The following is a description of a gene set: species: Mus musculus Mouse Gene Set: GOCC_NEURON_PROJECTION A prolongation or process extending from a nerve cell, e.g. an axon or dendrite., and this is the list of marker genes: Gabbr2, Homer2, Itsn1, Tmod2, Dlg3, Amfr, Npy1r, Clstn2, Rom1, Elmod3, Syt13, Chrna10, Aatk, Prnp, Hmcn2, Mir18, Psd2, Zfyve27, Polg, Hspa8, Drd1, Dlgap3, Tgfb2, Prcd, Fyn, Trpm5, Casc3, Ghsr, App, Grid2ip (glutamate receptor, ionotropic, delta 2 (Grid2) interacting protein 1), Iqcb1, Syp, Bnip3, Dynll1, Vti1a, Crhr1, Scn1a, Kcnip2 (Kv channel-interacting protein 2), Tubb3, Shisa9, Sstr1, Prkn, Sptbn1, Lama2, Lmtk2, Amph, Flrt3, Glrx2, Psmc2, Gabrb2, Zfp804a, Gabra3, Fas, Phaf1, Dlg4, Rgs9, Hif1a, Bbs2, Sod1, 4930544G11Rik, Vamp2, Cdh23, Chrm5, Brsk2, Ang, Nmb (NCBI Gene Id 68039), Cacng7, Vim, Arf4, Cldn5, Dbn1, Itpka, Abhd13, Plxdc1, Ephb1, Dynlt1f, Klhl17, Zmynd8, Kcnd2 (NCBI Gene Id 97339), Bace1, Cnga1, Pink1, Ptbp1, Ocm, Gpr19, Mertk, Arl8a, Grik3, Grik2, Zwint, Epha8, Pacsin1, Sptbn4, Prph2, Srsf10, Dync1i1, Vcan, Sh3kbp1, Spock1, Tenm1, Grm6 (NCBI Gene Id 216727), Lamp5, Nlgn4l, Cald1, Evx1, Diaph1, Tpx2, Agap2, Slc17a8, Htr1b, Ophn1, Cx3cr1, Nlgn1, Dcp1a, Ap1s1, Septin7, Plxnd1, Plekhg5, Chrm1, Casp6, Rara, Cntn1, Fbxw11, Cckar, Cplx2, Brinp2, Got1, Cd200l1, Hnrnpab, Rapgef4, Canx, Cript (cysteine-rich PDZ-binding protein), Htr1f, Nsg1, Morn4, Csnk1e, Becn1, Tmprss11c, Map6, Npy5r, Strn, Clrn1, Cacna1b, Arr3, Phlpp2, Cygb, Pcsk2, Mpdz, Ccng1, Grm7, Snph, Grk4, Mical1, Kcnq5, Calb1, Prkcg, Fat3, C9orf72, Prex1, Plk3, Myo7a, Palm, Hsp90ab1, Trpv4, Rpgrip1, Rab3ip, Gng3, Eif5a, Rpgr (retinitis pigmentosa GTPase regulator), Nr1d1, Pclo, Akap9, Ror2, Glrx, Ccl2, Cftr, Acte1, Anks1b, Agbl4, Hrh3, Inpp5f, Pals1, Rgs14 (NCBI Gene Id 51791), Glrb, Cdh2, Rhoa, Kcnn3, Trim3, Gabrg3, Apc, Mapt, Chrnb2, Cd200l2, Fbxo7, Aqp11, Brsk1, Shank1, Opn4, Aldoc, Arhgef7, Ddn, Rbm3, Sema3a, Ssh1, Cnga3, Nf2, Camk2g, Cabp1, Arf1, Grm1, Camk2n1, Rabgef1, Kcnq1, Ncf1, Hap1, Septin5, Prkcz, Hnrnpk, Mink1, Cbarp, Htr2a, Klc2, Lpar3, Taok2, Negr1, Map1a, Shisa7, Ppp5c, Snap47, Baalc, Prss12, Clip2, Map4, Neo1, Ero1a, Thy1, Fkbp1a, Srd5a1, Tgfb1 (transforming growth factor, beta 1), Arhgap33, Mark1, Atp8b1, Alk, Stim1, Coro1a, Nrp1, Mark3, Pdc (NCBI Gene Id 20028), Zpr1, Rimbp2, Cd40, Brinp3, Grm4, Ntrk1, Pum1, Cyba, Cdh1, Eea1, Adcy10, Ufl1, Nsmf, Erbb4, Mpst, Vstm5, Inpp5b, Eif4g2, Cntn2, Rap1gap2, Gdi1, Cybb, Htr7, Septin4, Apbb1, Nectin1, Myo1a, Dnm3, Nsf, Hnrnpa2b1 (NCBI Gene Id 71605), Lrp8, Slc25a27, Exoc4, Dmd, Atat1, Numb, Hrh4, Grk3 (NCBI Gene Id 320129), Kcnip4, Strc, Lrit1 (leucine-rich repeat, immunoglobulin-like and transmembrane domains 1), Grik4, Mlph, Ahcyl2, Dip2a, Cetn2, Slc38a2, Slc18a3, Inpp5k (NCBI Gene Id 192772), Lgi3, Trpv2, Cep250, Clrn2, Rtn1, Snapin, Atp6v0d1, Rgs8, Hip1r, Arpc2, Espn, Kif5c, Actb, Gabrb3, Sh2d3c, Slc38a1, Cdh13, Elk1, Chrna1, Htr5a, Rac3, Kcnc3, Ap3m1, Pak1, Kif13b, Myh14, Frmd7, Bcl11b, Ptprf, Ddc, Pqbp1, Cntn3, Opn1sw, Lrrc4b, Nrtn, Cdk5, Rpl26, Ptger4, Ptgs2, Ptprs, Dner, Smo, Met, Cbl, Dag1, Elavl4, Epha10, Syn1, Atp5mc1, Dip2b, Pde6b, Slc12a6, Aak1, Trim46, Plppr1, Srd5a2, Grp, Cntnap1, Rplp0, Rgs12, Kif5b, Actbl2, Prrt2, Mag, Ap3d1, Nos1, Prtg (protogenin), Nrp2, Cacna1c, Nrgn, Neurl1a, Mypn, Ago2, Zswim6, Bloc1s1, Grxcr1, Chl1, Bag2, Slc6a3, Whrn, Grin1, Guca1b, Dlg2, Synpr, Ppt1, Maco1, Nup42, Abi3, Kpna1, Dynlt1c, Sharpin, Gabre, Pcsk5, Glra1 (glycine receptor, alpha 1 subunit), Myl7, Ngfr, Rho (rhodopsin), Syap1 (NCBI Gene Id 67043), Mkks, Hsbp1, Cacna1h, Glra3, Cyth2, Chrna6 (cholinergic receptor, nicotinic, alpha polypeptide 6), Nek3, Ptbp2, Atp2b2, Atp1a2, Klhl14, Git1, Eif4b, Afdn (NCBI Gene Id 240024), Pde2a, Ntng2, Vip, Rbm8a2, Scn9a, Calm1, Cryab, Gnb3, Klhl20, Rtn2, Fubp3, Txn2, Dbh, Kcne3, Spa17, Lypd6, Sncg, Ift88, Prlhr, Ptprk, P2rx6, Cx3cl1, Ap3s1, Ush2a, Cacng3, Cntf, Slc32a1, P2ry1, Prkaa2, Mapk8 (mitogen-activated protein kinase 8), Tenm4, Braf, Slc8a1, Cpeb1, Pawr, Adcy9, Cux1, Asic2, Tmigd1, Ppargc1a, Gabra4 (gamma-aminobutyric acid type A receptor subunit alpha 4), Tiam1, Cpeb2, Gprin1, Dvl1, Tnk2, Grin3a, Il6st, Dctn2, Sarm1, Clasp2, Frmpd4, Rps6-ps4 (ribosomal protein S6, pseudogene 4), Tpm3, Abi1, Napepld, Npy, Nf1, Trak2, Fmr1, Caly, Rangap1, Dlgap4, Casr, Chrna9, Prkcb, Kcnip1, Hnrnpu, Brd1, Ocrl, Prr7, Tspear, Tnn, Unc13a, Esr1 (NCBI Gene Id 13982), Flrt1, Hdc, Ptpn9, Slc24a4, Snx18, Kif1c, Unc80, Rgs7, Pde6h, Itgb1, Nmnat3, Shh, Guca1a, Rab8a, Zfp385a, Adcy2, Abhd12, Hcn2, Unc5a, Hmbs, Eif4ebp2, Hsp90aa1, Eno2, Myc, Triobp, Adgrl3 (NCBI Gene Id 74495), Cacna1a, Pcare, Adnp, Katna1, Myo3b, Ntsr2, Hnrnpr, Fzd5, Rack1, Pias3, Trappc4, Reln, Mgll, Skor1 (SKI family transcriptional corepressor 1), Oprm1, Malat1, Rap1gap, Atp7a, Cask, Crtac1, Upf3a, Ncs1, Mrgpra3, Eif4a3l1, Atp13a2, Btbd8, Trpc2, Ppp1r9a, Bglap2 (bone gamma-carboxyglutamate protein 2), Dock4, Dock10, Adrb2, Acadm, Cadm1, Rgs17, Lrig2, Atxn1l, Ush1g (USH1 protein network component sans), Exoc6, Anxa5, Hspb1, Rap1a, Rogdi, Tmem222, Sybu, Ift20, Fstl3, Optn, Blvrb, Snx1, Ppp1ca, Mirc35hg, Pgrmc1, Doc2a, Cttnbp2, Samd14, Cacna1d, Dync1h1, Ift140, Mtor, Dctn1, Glul, Atp2b1, Ctnna2, Gria3, Ntf5, Nmnat2, Bmpr2, Igf2bp1, Glrx3, Ift52, Oprk1, Fscn3, Slc18a2, Ntf3, Mast1, Unc13c, Actn1, Apba3 (amyloid beta precursor protein binding family A member 3), Tsga10ip, Borcs5, Gabrr2, Crhbp, Arhgap4, Tanc2 (NCBI Gene Id 77097), Atp6ap2, Avil, Aldh1a1, Cnnm1, Apod, Sorbs2, Ptgdr2, Hrh2, Gng13, Npy4r (neuropeptide Y receptor Y4), Ighmbp2 (immunoglobulin mu DNA binding protein 2), Slc1a1, Kcna1, Ppp3ca, Tulp1, Atg16l1, Map7d2, Atp1a4, Dcx, Insr, Alox5, Lca5, Htr4, Nphp1, Chrna3, Camkk2, Dyrk1a, Glra4, Sv2a, Piezo2, Kcnn1, Gpr179, Dpysl5, Ubb, Lzts1 (leucine zipper, putative tumor suppressor 1), Kif1a, Rps3, Necab2, Ptpro, Opn5, Chrnb1, Slc1a4, Cntn4, Itga2, Anks1, Cpeb4, Crtc1, Syt8, Cnn3, Pard6a, Nrcam, Chrnb3, Calca, Tmem151a, Gria2, Hapln2, Agtr1a, Kcnk1, Ywhae, Kifap3, Ncdn, Tmem230, Ptprn2, Cxadr, Chrna7, Itpr2, Cib2 (calcium and integrin binding family member 2), Arrb2, Slc6a1, Mbp, Tprg1l, Rit2, Cyfip2, Cngb3, Myo3a, Mpp2, Tubb4a, Plcb4, Npcd (NCBI Gene Id 504193), Kcnab2, Itga3, Gars1, Igf1r, Trp63, Rdx, Gsk3a, Rnf6, Cplx3, Robo1, Ptchd1, Rgs10, Shank2, Rin3, Nrsn2, Pde4b, Ephb6, Ada, Nmu, Abhd17a, Rps6kb1, Ank3, Myo6, Pkhd1l1, Grip1, Crcp, Kif3a, Atoh7, Nectin3, Ptprn, Ptk2b, Klhl24, Bloc1s2, Alcam, Kirrel1, Ilk, Gpr149, Ctnnd2, Ache, Grk1, Synpo, Stmn2, Cd200, Sbf1, Cobl, Ngf, Inpp5a, Tsc1, Begain, Gfra1, Rp1, Ctsz, Slc9a5, Kcnk2, Cln3, Sptbn5, Cpne5, Pcdhb22, Asic1, Cacna1i (calcium channel, voltage-dependent, alpha 1I subunit), Ulk1, Hcn4, Chrnb4, Camk2b, Stat1, Epha7, Serpinf1, Pten (phosphatase and tensin homolog), Ucn, Bsg, Brinp1, Homer3, Kcnma1, Lpar1, Lynx1, Shisa6, Lrrk2, Exoc3, Ank1, Cacna1f, Lhfpl4, Cxcr4, Clu (NCBI Gene Id 28201), Sbf2, Syt11, Spast, Jph4, Spink2, Kcnh1, Pex6, Myo10, Llgl1, Atp1a3, Uchl1, Dab2ip, Ccdc120, Ntsr1, Adgrb1, Rps6, Gria4, Scn5a (sodium channel, voltage-gated, type V, alpha), Ssna1, Clcn2, Add1, Trpv1, Slc17a6, Cthrc1, Ubxn2a, Fzd4, Cnih2, Mob2, Sgce, Psd, Pcdhb16, Drd4, Klc3, Chrnd, Wls, Shank3, Epha3, Cdk5r1, Gjc2, Pgr, Mmp3, Myo9a, Ykt6, Rgs11, Calcr, Disc1, Stoml3, Ubxn1, Ucn3, C4a, Gldn, Magee1, Acad9, Ngdn, Nradd, Htr5b, Pcp4, Ccr2, Gabrb1 (NCBI Gene Id 320243), Chrna2, Atp1a1, Bin1, Nfib, Ghrl, Ceacam16, Copa, Lyar, Basp1, Npff, Atg7, Pde6a, Jam2, Asap1 (ArfGAP with SH3 domain, ankyrin repeat and PH domain1), Dtna, Lzts3, Ireb2, Ntrk3, Htr3a (NCBI Gene Id 15561), Eef2k, Gripap1, Flna, Cep290, Nr3c1, Grm5, Chrm4, Septin8, Elovl5, Trim9, Adam21, Gchfr (GTP cyclohydrolase I feedback regulator), Myh10, Cngb1, Stx4a, Ass1, Alpk1, Bdnf, Dscam, Mt3, Stmn4, Klc1, Cpe, Gphn, Pacrg, Psen1 (NCBI Gene Id 19164), Dcdc2a, Scn2a, Gc (vitamin D binding protein), Kcnn2, Dst, Tanc1, Abca4, Cdh9, Orai2, Bloc1s5, Srebf2, Samd4, Epha4, Epha5, Vps16, Eno1b, Ttyh1, Khsrp, Scn10a, Enah, Usp9x (ubiquitin specific peptidase 9, X chromosome), Htr6, Cntnap2, Septin11, Rtn4rl2, Gucy2f, Sstr2, Atp2b3, Plec, Arrb1 (arrestin, beta 1), Nrxn1, Igsf9b, Crh, Bloc1s6, Prph, Sort1, Magi2, Gnaq, Scrg1, Adra2c, Prkaa1 (NCBI Gene Id 105952), Sri, Tbcc, Kcnj4, Crp (NCBI Gene Id 98289), Htr1a, Eno1, Drd5, Rsph9, Scgn, Nqo1, Rin1, Strn3, Aurka, Snca, Dgki, Kif3b, Mapk1, Rab21, Gabra2 (gamma-aminobutyric acid type A receptor subunit alpha 2), Rac1, Cpt1c, Rcvrn, Syndig1, Trpm1, Prkca, Myoc, Gnat1, Dock7, Mapk8ip3, Vmn2r1, Ankrd24, Comt, Kcnk9, Pdyn, Kcnj6, Opn3, C1ql1, Stx3, Tpbg, Grid1, Terf2, Rab27a, Neu4, Ano2, Grin2a, Gria1, Scn1b, Atxn10, Sipa1l1, Syde1, Drd2, Pdzd7, Adam10, Kcna4, Spta1, Rbm8a, Clstn3, Unc5c, Ptk2, Fkbp4, Calm3, Atg5, Gper1, mt-Nd1, Ar, Apba2, Arhgap32, Rgs7bp, Fam107a, Pafah1b1, Adora1, Cpne6, Tph2, Hmgb1, Ica1, Avp (arginine vasopressin), Ap3m2, Kif1b, Slc17a7, Scn2b, Trpc5, Pabpc1, Slc9a6, Abi3bp, Npr2, Car2, Ube2i, Grxcr2, Bbs7, Minar2, Pls3, Arl8b, Kcnj2 (potassium inwardly-rectifying channel, subfamily J, member 2), Marcks, Kcnc2, Espnl, Ptgs1, Olfm1, Katnb1, Itga8, Nap1l4, Tor1a, Ndfip1, Tnfrsf1b, Dagla, Kcnq2, Pi4k2a, Vps35, Slc30a3, Bcan, Slc1a3, Map2 (NCBI Gene Id 17756), Mgarp, Nrsn1, Ptpn5, Ghrh, Pcdh15, Adcyap1, Kcnab1, Rab17, Chrne, Eif4a3l2, Rab5a, Igsf8, Ndel1 (NCBI Gene Id 83431), Ahi1, Camk2a, Nexn, Syt2, Tmem108, Kcnj11, Itga4, Fzd3, Ppp1r9b, Nxnl1, Cntn5, Sncb, Hcfc1, Ttll7, Tenm3, Eif2b2, Slitrk2, Ppfia1, Kndc1, Slc8a3, Cdhr1, Osbp2, Mtpn, Dlgap2, Rims2, Kcna2, Bcar1, Acvrl1, Dnm1, Ltbp1, Gipc1, Rtn3, Syt5, P2rx4, Grid2, Slc30a1, Map1b, Cd2ap, Irx3, Slc1a7, Rtn4r, Rpgrip1l, Nherf2, Il1r1, Nts, Nell2, Gpr161, Shtn1, Tprn, Fgf13, C4b, Synj2, Pjvk, Crhr2, Snap23, Synj1, Eif4a3, Zdhhc5, Cdh8, Shisa8, Map9, Ppp2r1a, Aqp1, Ntm, Omp, Tenm2, Spata7, Fbxo2, Myo1c, Nefl, Rnf112, Arfgef2, Dcc (DCC netrin 1 receptor), Sdccag8, Gabra5, Pdgfb, Iqschfp (Iqcj and Schip1 fusion protein), Map2k4, Ermn, Ncmap, Th, Rab3a, Hdac5, Eps8, Arhgap44, Slc4a8, Pcdh8, Mylk2, Tacr1, Wdr19, Slc18a1, Camk2d, Crmp1, Slc6a6, Cfh, Palmd, Agtpbp1, Lrp1, Itpr3, Slc1a2 (solute carrier family 1 (glial high affinity glutamate transporter), member 2), Insrr, Abl2, Opa1, Hrh1, Hspa5, Pnoc, Fam168b, Pura, Ap3b1, Gpr37, Klhl1, Eps8l2, Mtmr2, Loxhd1, Kcnj14, Sstr5, Micall2, Dynlt1b, Neto1, Adcy6, Scn4a, Hpca, Gna12, Cacna1s, Lmtk3, Stmn1, Twf2, Adcy8, Cdc42, Bloc1s3, Park7, Hcn3, Lsm1, Pick1, Cnnm4, Myot, Myo5a, Atl1, Pcdhgb1, Rapgef3, Ror1, Kcnb2, Sstr4 (somatostatin receptor 4), Ush1c, Dbnl, Ckb, Ccsap, Gata3un, Vezt, Myo5b, Slc6a2, Cadm2, Gigyf2, Madd, Ripor2, Ephb2, Ttc8, Kcnj12, Cnr1, Kcna3, Epm2a, Ndrg2, Amigo1, Gabarapl1, Trpm7, Rufy3, Sema6a, Ncoa2, Phb2, Pcsk1, Lrrtm1, Rab13, Myrip, Sirt2, Fkbp15, Flrt2, Cacng2, Atcay, Apoe, Zdhhc12, Pcdh9, Gngt1, Tiam2, Gabrg1, Lamp1, Erc2, Dennd1a (NCBI Gene Id 338506), Pip4k2a, Txnrd2, Bmpr1a, Gnai2, Mapk8ip1, Dnm2, Plekhb1, Calb2, Adora2a, Sez6, Tshz3, Slc38a7, Cyp11b2, Smurf1, Stau2, Bglap3 (NCBI Gene Id 99648), Gdpd5, Pde6g, Vamp3, Myo15a, Sfpq, Ift122, Gopc, Nlgn3, Fxr2, Grin2b, Anxa3, Pum2, Cck, Ppp1r1b, Ager, Limk1, Txn1, Slc5a7, Kif21a, Slc12a2, Impg1, Capn2, Adcy1, Gabrg2 (gamma-aminobutyric acid type A receptor, subunit gamma 2), Grk2, Calml3, Gsto1, Reg1, Asl, Slc12a5, Cetn3, Tmem266, Slc6a4, Dtnb, Kirrel3, Itpr1, Snx14, Rxra (retinoid X receptor alpha), Wdfy3 (NCBI Gene Id 72145), Gnb5, Auts2, Ntrk2, Sstr3, Copg2, Ppp2ca, Kcnd3, Abr, Trpa1, Nrdc (nardilysin convertase), Cldn11, Ppp1cc, L1cam, Nlgn2, Tsc22d4, Mcrs1, Gnao1, Stx1b, Tmc2, Cdk16 (NCBI Gene Id 18555), Baiap2, Actn4, Dicer1, Ston2, Nog, Arc, Ccdc66, Septin14, Chrna5, Mark2, Kif3c, Bmpr1b, Spg11, Rheb, Dmwd, Stxbp1, Fam161a, Clstn1, Ret, Reep6, Fez2, Slc4a7, Ctnnb1, Lrrc7, Robo3, Fxr1, Lhfpl5, Cplx4, Atf4, Srcin1, Cad, Abi2 (NCBI Gene Id 98436), Kcnd1, Srgap2, Tmem237, Cttn, Il1rapl1, Oprd1, Farp1, Crb1, Ppfia2, Cntnap3, Kif21b, Tacr3, Ap3b2, Rdh11, Grm2, Sdc3, Rp1l1, Hnf1a, Sorcs2, Adgrv1, Orai1, Actg1, Kif5a, Syncrip, Ift57, Emx2, Prkar2b, Cplx1, Nin, Aplp2, Mchr1, Rptor, Wdr47, Clcn3, Abhd17c, Pnmt, Pnliprp2, Grik1, Uhmk1, Stau1, Pdlim4, Scn3a, Cnr2, Kcnn4, Pou4f1, Ctla2a, Slc2a13, Sumo1, Grik5, Flot2, Dixdc1, Adcy4, Htr3b, Lrfn3, Cntnap4, Map3k12, Bloc1s4, Snap25, Scn11a, Acot7, Slc8a2, Tac1, Ifngr1, Inpp5j, Nphp4, Rd3, Fcgr2b, Cables1 (NCBI Gene Id 63955), Htr1d, Epb41l3, Mob4, Ybx1, Ppm1a, Gnas, Gsk3b, Epha6, Pygb, Fscn1, Rab39b, Nptn, Sirt1, Cmklr2, Cerkl, Kcnk4, Mme, Armcx3 (armadillo repeat containing, X-linked 3), Septin2, Rapgef2, Dpysl2, Rab27b, Cacng8, Iqgap1, Lrp2, Maf1, Mark4, Mcoln3, Robo2, Cib1, Luzp1, Ap3s2, Gap43, Gabbr1, Acap3, Gabrd, Map1s, Sphk1, Rasgrf1, Nefh, Htr2b, Gabra6, Kcnc4, Kif17, Dnajb1 (NCBI Gene Id 81489), Sema4f, Tspoap1, Ckap5, Gad2, Cyp19a1, Tbc1d24 (NCBI Gene Id 224617), Dclk1, Mak, Pard3, Emb, Kptn (kaptin), Src, Npbwr1, Smn1, Tpgs1, Caprin1, Lgi1, Bptf, Npy6r, Abl1, Lrp4, Adra2a, Nsg2, Ptger3, Kcnip3, Gnrh1, Abitram, Grip2, Syt1, Scn8a, Fez1, Creb1, Igsf9, Palld, Slc7a10, Chrna4, Stx1a, P2rx2, Sptan1, Ctnnd1, Slc4a10, Gnaz, Exoc8, Pebp1, Abhd17b, Arpc3, Cd3e, Rgs9bp, Penk, Sigmar1, Adam11, Prom1, Nefm, Ppp1r2, Cacna1g, Efnb2, Hcn1, Cetn1, Il31ra, Stmn3, Arhgef2, Cdkl5, Fchsd2, Sag, Htr2c, Ephb3, Tph1, Vsig10, Drp2, Fus, P2rx3, Fscn2, Hdac6, Kcnb1, Mycbp2, Gad1, Syngap1, Elfn1 (leucine rich repeat and fibronectin type III, extracellular 1), Nav1, Lrit3, Ldlrap1, Unc13b, Dnaaf4, Ccn3, Agrn, Gucy2e, Boc, Gpm6a, Ric3, Ncam2, Spg7, Maob, Impa1, Bcr, Nrn1l, Wfs1, Htt, Strn4, Mdga1, Syt7, Chrm3, Cdk5r2, Pls1, Inha, Cpeb3, Akap5 (NCBI Gene Id 70774), Map7, Ptch1, Dpysl3, Oprl1, Dhx36 (NCBI Gene Id 99809), Arhgef15, Map2k1, Poc5, Grm3, Trak1, Map1lc3b, Cdc14a, Rgs6, Tsga10, Mir133b, Cyfip1, Uri1, Arl3, Chat, D630045J12Rik, Myo1d, Cst3, Dynlt1a, Adam22, Prr12, Ptprz1, Calm2, Timp2 (tissue inhibitor of metalloproteinase 2), Slit2, Kcnq3, Tsc2, Ngef, Trf, Ift56, Rasgrp2, Rpl28, Tnfrsf1a, Kif2a, Nherf1, Tmc1, Setx, Clic5, Dtnbp1, Mpp4, Max, Chrng, Opn1mw, Glrx5, Sh3gl2, Dlg1 (NCBI Gene Id 320792), Syt4, Als2, Pvalb, Cfl1, Cfap410, Xrn1, Bsn, Pex5l, Exoc7, Rtn4, Kncn, Tmem185a, Cyp17a1, Tubg1, Septin6, P2rx7, Gnat2, Oxt, Capzb, Slc38a8, Dscaml1, Lrrc4, Git2, Piezo1, Vps13a (NCBI Gene Id 78932), Numa1, Kcna6, Apba1, Chrm2, Bbs4, Arpc5, Topors, Usp8, Azin2, Ptpn6, Kcnc1, Snap91, Hycc1, N4bp3, Nfasc, Mul1 (mitochondrial ubiquitin ligase activator of NFKB 1), Cyp46a1, Cntn6, Homer1 (homer scaffolding protein 1), Cnih3, Gabra1, Ncam1, Rph3a, Vamp1, Plk2, Ranbp1, Ankrd27, Nrg1, Otx2, Bglap, Adora3, Adgrl1, Zc3h14, Kif20b, Enpp1, Mpp1, Ptprq, Gnb1, Pdgfra, Rhoc